Given this list of marker genes Eif3d, Rps26, Rpl38, Rps13, Rps4x, Eif1ax, Rps24, Eif3i, Rpl3l, Rpl7, Rps15, Rps19, Rpl11 (ribosomal protein L11), Rpl36al, Rpl9, Rpl37, Rpl15, Eif3j2, Rpl37a, Fau, Rpl14, Rpl18, Rps7, Rpl27a, Rps17, Rpl39l, Rpl29, Rpl4, Rps28, Eif3k, Rpl36a, Ubb, Eif3b, Eif5b, Rps6, Eif3e, Rps12, Rps5, Rps25, Eif4a2, Eif4a1, Rps10, Rpl26, Rps27l, Rpl19, Rpl24, Rpl37rt, Rpl18a, Rpl12, Eif3f, Rpl13, Eif3g, Rps9, Rpl27, Rps8, Rpl39, Rps23, Rpl23a, Rplp2, Eif2s3x, Rps2, Rpl6, Rps20, Rps18, Rps11, Rpl3, Rps3a1, here is a description of the gene set: Reactome Pathway: GTP hydrolysis and joining of the 60S ribosomal subunit studied in species Mus musculus part of: Cap-dependent Translation Initiation electronically inferred by orthology from the curated human pathway This event has been computationally inferred from an event that has been demonstrated in another species.<p>The inference is based on the homology mapping from PANTHER. Briefly, reactions for which all involved PhysicalEntities (in input, output and catalyst) have a mapped orthologue/paralogue (for complexes at least 75% of components must have a mapping) are inferred to the other species.